The following is a description of a gene set: Human Gene Set: GOBP_HISTONE_MRNA_METABOLIC_PROCESS The chemical reactions and pathways involving an mRNA encoding a histone. species: Homo sapiens, and this is the list of marker genes: CPSF2, LSM11, TENT2, NCBP1, XRN1, UPF1 (NCBI Gene Id 5976), SSB, LSM10, ATM, ERI1, MBLAC1, ZNF473, EXOSC10, NCBP2, TUT4, TUT1, DCP2, CPSF3, TENT4B, SLBP, TUT7, MTPAP, EXOSC4, LSM1